The following is a description of a gene set: Tumors contain a fraction of cancer stem cells that maintain the propagation of the disease. The CD34(+)CD38(-) cells, isolated from acute myeloid leukemia (AML), were shown to be enriched leukemic stem cells (LSC). We isolated the CD34(+)CD38(-) cell fraction from AML and compared their gene expression profiles to the CD34(+)CD38(+) cell fraction, using microarrays. We found genes that were at least twofold over- or underexpressed between the two cell populations. These include underexpression of DNA repair, signal transduction and cell cycle genes, consistent with the relative quiescence of stem cells, and chromosomal aberrations and mutations of leukemic cells. Comparison of the LSC expression data to that of normal hematopoietic stem cells (HSC) revealed that 34% of the modulated genes are shared by both LSC and HSC, supporting the suggestion that the LSC originated within the HSC progenitors. We focused on the Notch pathway since Jagged-2, a Notch ligand was found to be overexpressed in the LSC samples. We show that DAPT, an inhibitor of gamma-secretase, a protease that is involved in Jagged and Notch signaling, inhibits LSC growth in colony formation assays. Identification of additional genes that regulate LSC self-renewal may provide new targets for therapy. from publication Gal H, Amariglio N, Trakhtenbrot L, Jacob-Hirsh J, Margalit O, Avigdor A, Nagler A, Tavor S, Ein-Dor L, Lapidot T, Domany E, Rechavi G, Givol D (PMID 17039238) studied in species Homo sapiens Genes down-regulated in leukemic stem cells (LSC), defined as CD34+CD38- cells from AML (acute myeloid leukemia patients) compared to the CD34+CD38+ cells. Human Gene Set: GAL_LEUKEMIC_STEM_CELL_DN, and this is the list of marker genes: ERMAP, ITGA2B, IFNA4, ENC1, IGSF6, LINC01013, LGALS2, SMC2, NCF1 (neutrophil cytosolic factor 1), LYPLA2, CCNB1 (cyclin B1), HAL, SCNN1A, NPAS3, COL18A1, CAPG, FCN1, CCL5, CEBPE, VAMP1, TYMS, BUB1B, COL6A2, LYZ, NCAPG, CSTA, FGR, ORC1, SLC16A6, TNS1, IGKC, VSIG4, ALPP, FPR1, FGGY, ZNF589, KLK6, TRGC1, CARD9, IL1RN, TOP2A, PLK1, IGLL1, TUBB2B, GPC5, CST4 (cystatin S), ACAA2, FCGR2A, S100P, LGALS3, TYMP, CDC45, GTSE1, RRM2, NDRG2, KIF20A, MELK, SLC15A3, LAMA4, IFI30, IGFBP7, TMEM161A, CDC42EP3, OR2F2, CASP1, GINS2, SAC3D1, LILRB4, ZWINT, ZFY, POLA2, CD163, E2F1, HOMER3, LINS1, CX3CR1, MAPK13, C1QA, ADAP2 (NCBI Gene Id 55803), SMC1A, LILRB3, AOAH, MEGF6, CEBPD, NUSAP1, IL2RB, VDR, GIMAP5, NR4A1, THOC5 (NCBI Gene Id 8563), FEN1, LILRB1, C3AR1, CENPA, SECTM1, P2RX5, SERGEF, RLIG1, PTGER3, CDK1, CD93, UTP25, ONECUT2, ARHGEF15, CCR1, ALDH1L1, CCL4, AP1S1, KIFC1, ELANE (NCBI Gene Id 6417), CENPM, LMNB1, TMEM53, CA12, CCNA2, SHCBP1, CYP1B1, FCAR, ASF1B, BUB1, CD1D, TLR2, GM2A, COCH, FGL2 (fibrinogen like 2), UBE3B, PCLAF, CCNB2, SLC11A1, DLX4, MRC2, TRAC, PRKG2, APOOL, PRTN3, HCAR3, RNASE2, FER1L4, SERPINA1, PRMT7, CLC (Charcot-Leyden crystal galectin), CD38, CDC25C, FGF21, IGFBP2, CDC20, ADCY2, G0S2, MAFB, MMP9, H4C7, GALNT12, USP46, PPP1R12B, RRAD (NCBI Gene Id 6236), MAGEF1, HMMR, SAMHD1, PRDM1, CD226, SPATA6 (NCBI Gene Id 54558), FCGR1A, CTSG, RAD51, MS4A6A, LRRC49, GGT5 (gamma-glutamyltransferase 5), MOSPD3 (motile sperm domain containing 3), FNTB, HPSE, MS4A4A, AZU1, MINPP1, PALB2, SIRPA (signal regulatory protein alpha), PASK, VCAN, CACNA1G, DNAAF1, NCF2, TNFAIP6, TEP1, GPR18, MNDA, PLAA (NCBI Gene Id 9373), ALB, PILRA, HNMT, LETM1 (NCBI Gene Id 3954), GPR65, CEP112, POLM, CDC6, CD14, CXCR3, IGLC2, BIRC5, NIPAL3, S100A8, S100A12, LIG1, NAP1L1 (NCBI Gene Id 64165), TEX14, CHST15 (carbohydrate sulfotransferase 15), MS4A3, SLC22A4, TPI1, CADM3, LILRA2, CDCA8, CDKN3, ART1, GDF3, CLEC5A, ADCK2, E2F2, LGALS1, DMXL2, ALDH4A1, PRUNE1, STX11, KIF18B, LRP2, S100A9, H3C2, OSGIN2, MOGS, DHFR, E2F8, CXCL1, DES, ESPL1, CD86, IL1B (NCBI Gene Id 3553), REST, SLC6A6